Given this list of marker genes Wipi2, Ulk3, Atg4c, Atg4a, Wdr45, Ulk2, Snx7, Ulk1, Atg4d (NCBI Gene Id 235040), Atg3, Atg12, Atg7, Wdr45b, Atg5, Atg2b, Snx30, Wipi1, Atg13, Atg9a, Atg2a, Atg4b, Rb1cc1, Atg4a-ps (autophagy related 4A, pseudogene), Atg9b, here is a description of the gene set: Mouse Gene Set: GOBP_NUCLEOPHAGY species: Mus musculus A form of autophagy, by which damaged or non-essential parts of the nucleus, or even an entire nucleus is degraded.